The following is a description of a gene set: from publication Browne EP, Wing B, Coleman D, Shenk T (PMID 11711622) The effect of human cytomegalovirus (HCMV) infection on cellular mRNA accumulation was analyzed by gene chip technology. During a 48-h time course after infection of human diploid fibroblasts, 1,425 cellular mRNAs were found to be up-regulated or down-regulated by threefold or greater in at least two consecutive time points. Several classes of genes were prominently affected, including interferon response genes, cell cycle regulators, apoptosis regulators, inflammatory pathway genes, and immune regulators. The number of mRNAs that were up-regulated or down-regulated were roughly equal over the complete time course. However, for the first 8 h after infection, the number of up-regulated mRNAs was significantly less than the number of down-regulated mRNAs. By analyzing the mRNA expression profile of cells infected in the presence of cycloheximide, it was found that a minimum of 25 mRNAs were modulated by HCMV in the absence of protein synthesis. These included mRNAs encoded by a small number of interferon-responsive genes, as well as beta interferon itself. Cellular mRNA levels in cytomegalovirus-infected cells were compared to the levels in cells infected with UV-inactivated virus. The inactivated virus caused the up-regulation of a much greater number of mRNAs, many of which encoded proteins with antiviral roles, such as interferon-responsive genes and proinflammatory cytokines. These data argue that one or more newly synthesized viral gene products block the induction of antiviral pathways that are triggered by HCMV binding and entry. Genes down-regulated in primary fibroblast cell culture point after infection with HCMV (AD169 strain) at 2 h time point that were not down-regulated at the previous time point, 1 h. Human Gene Set: BROWNE_HCMV_INFECTION_2HR_DN studied in species Homo sapiens, and this is the list of marker genes: CENPA, STIP1, DST, COL13A1 (collagen type XIII alpha 1 chain), CENPF, ERCC6, SERPINE1, CDC42EP2, IGFBP5, SNAI2, DUSP6, F3, SGK1, TTC9, RAB3B, ITGA2, PRIM2, ITGA6, TK1, KRT19, TPM2, GCDH, MAB21L1, ANXA2, DGKE, MMP3, PAK2, NAP1L1 (NCBI Gene Id 64165), BIRC5, TCP11L1, TNP2, LPXN, YLPM1, KIF23, CENPE, RAD23A, UBE2C, MYC, AXL, PLAUR, CDKN1B, ABCC1, NPTX1, H1-2, ITGA3, PTPRR, IFIT2, CYP2J2